Given this list of marker genes ATN1, GNB2, COQ4, SIX6, PRKACB, DPYSL5, RPS24, ALDH1A2, NKAP, GJA5, DLG5, WBP4, NUP107, XYLT1, THOC6, TBX3, NODAL (nodal growth differentiation factor), CCDC174, STX1A, MKKS, TNNT2, PLD1, YY1AP1, LARS2, EVC2, CTCF, SKIC2, GET3, NAA20, GRIN1, SALL1, PRKACA, WBP11, ARID2 (NCBI Gene Id 57676), RPS29, FH, MYPN, SATB2, NIPBL (NIPBL cohesin loading factor), B3GALT6, ALG12, ALPK3, FRA10AC1 (FRA10A associated CGG repeat 1), NEK1, GLA, ALG8, FBN2, AHDC1, PEX2, TKT, MYH7, ELN, TMEM260, RPL10, BMP2, MED23, PDHA1, SLC37A4, CCND2, RPL27 (NCBI Gene Id 6155), ERI1 (exoribonuclease 1), DLK1, NEUROD2, GDF1, GATA5, DPH1, MYH3, KLHL41, DST, FIBP, DLL4, VPS13B, SYNE1, PKD1L1, PEX16, WDR37, RAB34, IFT56, DNMT3A, MYCN, DMXL2, GLI3, CKAP2L, ABL1, HRAS, AFF4, SPEN, CCDC47, TNFRSF11A, RYR1, EXOC2, NFIX, RPL15, KAT6A, TXNL4A (NCBI Gene Id 10907), TRAIP, FILIP1, MTFMT, EHMT1, VIPAS39, LEMD2, MID1, ATRX, DHCR7, HYMAI, EOGT, PEX13, RPL5, NDUFB11, MEIS2, PRDM13, METTL27, NR2F2, RPL35, STAG1, RPS19, PEX26, ADAMTS17, KIFBP, PIGQ, BAP1 (NCBI Gene Id 8314), RPS20, ERBB3, RAD21, RPS7, FGFRL1, CDK13, CLIP2, FOCAD, CALM3, GNAO1, ALG9, PEX14, DOHH, MMP2, FBN1, PEX10, LRP2, VPS35L, NXN, ODAD1, TALDO1, ODAD3, GYG1, CANT1, SCAF4, GATA4, HNRNPK, ARSL, DNAJC19, ADA2, TPR, RREB1, UMPS, INSR, CARS1, GTF2H5, ARID1A, POLR1A, CPLX1, ASXL1, SATB1, RPS26, SHANK3, TRIO, PIK3CA, HDAC8, GLI1, MICU1 (mitochondrial calcium uptake 1), CCDC22, RPS17, PIEZO2, RRAS2 (RAS related 2), ZNF462, POLA1, FLI1, NDUFC2, XYLT2, TP63 (tumor protein p63), SETD5, SCN2A, DNAJC30, CREBBP, ANKRD11, CAMK2A, ACADVL, TCTN3, RBM8A, PEX12, ATP6V1A, FKBP6, GRM7, ARID1B, SMAD2, FTO, ARHGAP31, PLXND1, TGDS, LRP5, DPH2, AXIN1, C2CD3, PPM1D, ECHS1, MPLKIP, UBR1, RPL35A, PPP2R5D, STAMBP, CSRP3, KDM6A, NCF1, MLXIPL, DGCR8, FADD, TRRAP, TAF6, SLF2, IPO8, HEATR3, CHRM3, NSD2, PIGL, FOXC2, TMEM237, LZTR1, GTF2IRD2, TSR2, SLC19A2, MYOCD, PPP2CA, KRAS, MED25, BRF1, GATA6, ADAMTS10, RAC1, PAH, COX7B, PEX1, UBR7 (ubiquitin protein ligase E3 component n-recognin 7), AKT3, EP300, PPP1CB, SMG8, CDC45, IDH1, GTF2IRD1, FANCI, WAC, DTNA, PUF60, RERE, B3GLCT, NEK9, RPL3L, ARVCF, CDK8, IFT27, KDM3B, SMARCD1, NAE1, CASK, UBE3B, SOS1, PPP1R13L, SOX11, MED12, SALL4, FGFR2, RAI1, MAP2K1, DAW1, ARCN1, CCDC32, VAC14, TAB2, CACNA1D, EFTUD2, EXT2, LONP1, NONO, GP1BB, TBX1, TAPT1, DYNC2I1, FANCB, RPS27, VPS33B, KAT5, SLC32A1, GTF2I, RAP1B (NCBI Gene Id 5908), HIRA, GATA1, WDR26, MT-CYB (mitochondrially encoded cytochrome b), RFC2, ZFX, MEOX1, DGCR6, TUBG1, PORCN, SMAD4, MAPK1, HCCS, DPH5, PEX5, CEP290, NF1, CWC27 (CWC27 spliceosome associated cyclophilin), BCR, RIT1, SH3PXD2B, CHD7, TRAF7, RSPO2, SVBP (small vasohibin binding protein), CIROP, TARS1, CCBE1, FANCC, BCOR, SMARCC2 (NCBI Gene Id 6601), SF3B4, JAM3, MAP2K2, MMP14, AARS1, COMT, RPL18, MACF1, AMER1, CEP57, DSG1, PSMD12 (NCBI Gene Id 5718), CITED2, UBE2A, TMEM94, NIPA2, LIMK1, CDKL5, HYLS1, PHGDH, SPTBN1, GJA8, RTL1, GDF6, ZEB2, KDM5A, IFT81, SLC29A3, SEC24C, SOS2, WT1, RRAGC, TBL2, WNT4, SMC1A, SIK1, PACS2, GDF3, ZBTB7A, DVL3, GPC4, DDX59, BUD23, TMEM53, DPF2, ALKBH8, SEC31A, ESS2, FGFR1, EIF4H, NOTCH1, SKIC3 (NCBI Gene Id 9652), SHOC2, DGCR2, GPC6, CTBP1, WASHC5, RNU4ATAC, KAT8, SMN1, ERCC2, RPL9, JMJD1C, CHD4, KCNA1, STRA6, SLC12A2, RPS10, OTUD6B (OTU deubiquitinase 6B), PGM1, CLXN, TGFB3, SF3B2, ERCC3, SMARCB1, TBX5, TCIRG1, APC2, SMARCA4, NAA10, TBC1D24, IFT172, MED13L, SMG9, ESCO2, IGBP1, OTUD5, PEX3, NIPA1, PEX19, UQCRFS1, BRAF, TRIM8, CHST3, KMT2D, CTU2, ROR2, SOX4, TASP1, FIG4, MYRF, BAZ1B, GJA1, CRKL, DYNC2LI1, PACS1, JAG1, CUX1, KAT6B, MGP, MYBPC3 (myosin binding protein C3), RNU4-2, GTF2E2, PLAGL1, EVC, DVL1, SNRPB, RPL11, MIR17HG, SON, NEDD4L, FOXF1, CRB2, PTPN11, MGAT2 (alpha-1,6-mannosyl-glycoprotein 2-beta-N-acetylglucosaminyltransferase), MEG3, IGF1R, PEX11B, SOX2, HNRNPR, NOTCH2, NKX2-6, NKX2-5, SMC3, YARS1, CD96, TFAP2B, MASP1, SMARCE1, ZNF699, KANSL1, PSMC1 (proteasome 26S subunit, ATPase 1), NKX2-1, LETM1 (leucine zipper and EF-hand containing transmembrane protein 1), PLCH1, PI4KA, NDUFB7, RPL8, NUP188, LBR, GPC3, UFD1, PNKP, ARX, CHD3, HOXA13, RAB23 (RAB23, member RAS oncogene family), DYRK1A, PQBP1, ATP6V0A2, RPL31, PPFIBP1, ZMYM2 (NCBI Gene Id 7750), VPS37D, ECE1, RPS28, PEX6, NOTCH3, PIK3R2, RPL26, RARB, TTC7A, CACNA1C, MAP3K7, CHMP1A, ZIC3, COG6, BRD4, LTBP2, FLNB, BSCL2, TMEM270, PALB2, RPS15A, RFX7, STAG2, STX5, SCN1B, SLC25A22, TBCK, DDX11, SPECC1L, TET3, CSGALNACT1, MYL2, TAOK1, TIAM1 (NCBI Gene Id 7074), ACVR2B, RNF113A, PIGP, NSD1, COG7, here is a description of the gene set: species: Homo sapiens Abnormal ventricular septum morphology A structural abnormality of the interventricular septum. Human Gene Set: HP_ABNORMAL_VENTRICULAR_SEPTUM_MORPHOLOGY